Given this list of marker genes BMP4, SMO, POU5F1, MESP1, BMP2, ROBO1, GATA5, ROBO2, DKK1, here is a description of the gene set: Human Gene Set: GOBP_REGULATION_OF_HEART_MORPHOGENESIS species: Homo sapiens Any process that modulates the frequency, rate or extent of heart morphogenesis.